The following is a description of a gene set: This event has been computationally inferred from an event that has been demonstrated in another species.<p>The inference is based on the homology mapping from PANTHER. Briefly, reactions for which all involved PhysicalEntities (in input, output and catalyst) have a mapped orthologue/paralogue (for complexes at least 75% of components must have a mapping) are inferred to the other species. Reactome Pathway: Cell Cycle studied in species Mus musculus electronically inferred by orthology from the curated human pathway, and this is the list of marker genes: Kif2c, H2ac4 (H2A clustered histone 4), H2bc11, Cenpj, Rae1, Rnf168, Fbxl7, Oip5, H2ac23, H4c18, Psma5, Psma1 (proteasome subunit alpha 1), H2ac6, Ppp2r2a, Orc3, H4c14 (H4 clustered histone 14), Rps27a, Cdkn2b, Ywhah, Gorasp1, Hjurp, Ube2s, Kpnb1, Ncaph, Cep72, Cul1, Cables1, Ncapd3, H3c7, Optn, Ankle2, Rad1, Mapk14, Ten1, Tfdp1, Psmc2, Brcc3 (NCBI Gene Id 210766), Top3a, Haus8, Mis12, Firrm, Zwilch, Psma6, Tubb4b, E2f1, Prkar2b, Lin52, Blm, Lcmt1, Pole, H2ac8, Mcm7, H3c11, Anapc2, H2bc3, Sumo1, Wee1, Cdk11b, Gmnn (NCBI Gene Id 57441), Gins3, Wrap53, Tubb2b, Ccne2, Pole2, Nup205, Ticrr, Dbf4, Npm1, H4c4, Ndc80, H2bc12, Seh1l, Psmb5, Ccne1, Cdc26 (cell division cycle 26), Chtf8 (CTF8, chromosome transmission fidelity factor 8), Csnk2b, H3c3, Phf20, Dync1li2, Obi1, Cenps, H3c15, Pold1, Smc3, H2ac24, Ncapg2, Trp53, Bora (NCBI Gene Id 77744), Csnk1a1, Psmd7, Ccnb1, Ube2c, Dmc1, Ctc1, H2ac15, Lin37, Pias4, Bard1, Pold2, Nek11, H2ac20, Blzf1, Aaas, Ndel1, Dna2, Tuba4a, Anapc7, Nup155, Orc5, Cep63, Xpo1, Fignl1, Rab1b, Emd, Cdc14a, H4c9, Cdk4, Tubb4a, H2ac19, Psma3, Cep43, Mapk11, Stag1, H2ac22 (NCBI Gene Id 319170), Phlda1, H2ac12, Rfc3, Nup42, Cep131, Tert, Tuba8, Tubgcp3, Terf1, Mdc1, Spc24, Cenpx, Cep135, Sfn, H2ac13, H2bc8, Prim1, Rfc1, Tpx2, Babam1, Tuba1a, Anapc10, Nup133, Sfi1, Psmb7, Pola2, Rbl2, Ran, Mad1l1, Lin54, Ywhae, Ppp2r1b, Cdkn1a, Ube2n, Lmna, Anapc15, Nup93, Mcm2, Psmd13, Pola1, Cenpa, Fkbpl, Hdac8, Sdccag8, Rad9a (RAD9 checkpoint clamp component A), Csnk1e, Cenpn, Psmb4, Smarca5, Acd, Cep290, H4c11, Rbbp4, Pif1, Kat5, Wrn, Cenpq, Nup85, Cdc45, Cenpm, Ccnh, Ndc1, H2bc13, Kif2b, H4c8, Psmb6, H4c3, Zfp385a, Ppp2r5a, H3c6, Gins1 (NCBI Gene Id 69270), Mzt1, Prkca, Cep57, H3c4, Mcm8, H2ac7, Ube2e1, H3c2, Mre11a, Fzr1, Haus1, Lbr, Nup54, Cdc6, H4c6, Tuba1c, Daxx, H4c12, Nde1, Orc1, H3c13, Tuba1b, Ccnd1, Trp53bp1, H2bc15, Gtse1, Plk1, Ppp2r5d, Psmd6, H2bc7, Psmc1, Psma7, H2ac10, Pcna, Pold4, Cenpu, Rbbp8, Lmnb1, Esco1, Ccna1, Aurkb, Nup210, Kntc1, Esco2, Psmc6, Ninl, Cdc7, Cenpt, Nup58, H2bc22, Mad2l1, H3c8, H2ac1, Orc4, Eml4, Ubb, H2bc27, Nbn, H2bc9 (NCBI Gene Id 319182), Cenpe, Cdc23, Tuba3b, Ist1, Ppp6c, Tubal3, Haus7, Hmmr, H2bc1, Tubgcp6, H2az2, Dynll1, Ajuba, Psma4, Golga2, Nudc, Tubb6, Brca1, Terf2, Rbbp7, Ska1, Vrk1, E2f3, Chek2, H3c10, H4c2, Cc2d1b, Rpa1, Mapk3, Psmd12, Cdkn1b, Clasp1, Chmp2a, H4c17, Cdkn1c, Itgb3bp, Psmc4, Cdk1, Psma2, Prkaca, Cep192, Psmd1, Psmc5, Rad21, Hus1, Chtf18, H2ax, Cep152, Cdc25c, Actr1a, Nedd1, Dscc1, Psmc3, Rab8a, B9d2, H3f3a, Ube2d1, Ppp2r5b, Chmp2b, Nop10, H4c1, Mcm4, Ppme1, Dctn1, Lig1, Tubgcp2, Kif20a, Rab1a, Rb1, Vrk2, H3c1, Shq1, Ctdnep1, Haus5, Cep41, H2ac11